The following is a description of a gene set: Reactome Pathway: Synthesis of Leukotrienes (LT) and Eoxins (EX) part of: Arachidonate metabolism studied in species Mus musculus This event has been computationally inferred from an event that has been demonstrated in another species.<p>The inference is based on the homology mapping from PANTHER. Briefly, reactions for which all involved PhysicalEntities (in input, output and catalyst) have a mapped orthologue/paralogue (for complexes at least 75% of components must have a mapping) are inferred to the other species. electronically inferred by orthology from the curated human pathway, and this is the list of marker genes: Cyp4f15, Cyp4f18, Cyp4a31, Lta4h, Cyp4a30b, Alox15 (NCBI Gene Id 11687), Alox5ap, Ggt1, Ltc4s, Cyp4a12a, Cyp4a10, Cyp4b1, Cyp4f39, Cyp4f40, Ggt5, Dpep1, Dpep2, Cyp4a29